Given this list of marker genes CDCA4, EFNB2, KIF23, OTX1, EYA1, HSPG2, CCND1, RSPO3, CPEB2 (cytoplasmic polyadenylation element binding protein 2), ESRRA, KCNAB1, AKT3, ACVR2A, PRDM4 (PR/SET domain 4), DLL1, PEDS1-UBE2V1, WNT2B, BTRC, ADAMTS3, UBE4B, SNX16, MOB4, PIM1, CDC42, HOXC8, HNRNPA1, FOSL1, SPTLC1, HOXA3, PAFAH1B1, PTCH1, CCND2 (NCBI Gene Id 894), BTG2, CDK5R1, MACF1, CPD, TRIM36, BPTF, PCDH9, WBP11, WSB1, ARL2, WWP1, BMPR1A, GPR63, HAS2, DEDD, KCNQ5, SMAD7, RECK, DNAJA2, HMGA2, FGF7, SELENOI, KANK1, KCNJ2, FGF2, KIF21A, CDC25A, TLK1, E2F3, MAP2K4, BCL2L2, PLAGL1, PTPN3, LUZP1, WEE1, KPNA3, PLAG1, ZNF423, BCL2, PPRC1, AGO4, PDCD4, PRKAR2A, PCDHAC1, SPEG, TGIF2, PCDHAC2, PTH, CRKL, WNT3A, USP15, RASSF5, PAPPA, GHR (NCBI Gene Id 2690), SOX5, CYP26B1, CCNE1, E2F7, UBE2V1, KDSR, here is a description of the gene set: species: Homo sapiens Potential targets of MIR15A and MIR16-1 microRNAs in prostate cancer. Human Gene Set: BONCI_TARGETS_OF_MIR15A_AND_MIR16_1 from publication Bonci D, Coppola V, Musumeci M, Addario A, Giuffrida R, Memeo L, D'Urso L, Pagliuca A, Biffoni M, Labbaye C, Bartucci M, Muto G, Peschle C, De Maria R (PMID 18931683) MicroRNAs (miRNAs) are noncoding small RNAs that repress protein translation by targeting specific messenger RNAs. miR-15a and miR-16-1 act as putative tumor suppressors by targeting the oncogene BCL2. These miRNAs form a cluster at the chromosomal region 13q14, which is frequently deleted in cancer. Here, we report that the miR-15a and miR-16-1 cluster targets CCND1 (encoding cyclin D1) and WNT3A, which promotes several tumorigenic features such as survival, proliferation and invasion. In cancer cells of advanced prostate tumors, the miR-15a and miR-16 level is significantly decreased, whereas the expression of BCL2, CCND1 and WNT3A is inversely upregulated. Delivery of antagomirs specific for miR-15a and miR-16 to normal mouse prostate results in marked hyperplasia, and knockdown of miR-15a and miR-16 promotes survival, proliferation and invasiveness of untransformed prostate cells, which become tumorigenic in immunodeficient NOD-SCID mice. Conversely, reconstitution of miR-15a and miR-16-1 expression results in growth arrest, apoptosis and marked regression of prostate tumor xenografts. Altogether, we propose that miR-15a and miR-16 act as tumor suppressor genes in prostate cancer through the control of cell survival, proliferation and invasion. These findings have therapeutic implications and may be exploited for future treatment of prostate cancer.